Given this list of marker genes FMR1, AGO1, PUM1, RBM4, RBM10, ELAVL1, DND1, HNRNPA2B1, AGO2, NEAT1, HOTTIP, LIN28A, SOCS3, ZNF697, ZC3H7B, ZC3H7A, SPOUT1, AGO4, SMAD5-AS1, AGO3, YBX1, HNRNPA1, TARBP2, TRIM71, TUT4, ZNF346, DNM3OS, DDX21, MATR3, TUT7, SOX2, TUSC8, POU5F1, OIP5-AS1, PNPT1, RC3H1, QKI, ZC3H12A, SOX4, ZC3H10 (zinc finger CCCH-type containing 10), LINC-ROR, XIST, PUM2, MALAT1, here is a description of the gene set: Binding to a microRNA, a 21-23 nucleotide RNA that is processed from a stem-loop RNA precursor (pre-miRNA) that is encoded within plant and animal genomes. Human Gene Set: GOMF_MIRNA_BINDING studied in species Homo sapiens